The following is a description of a gene set: studied in species Homo sapiens Any process that increases the frequency, rate or extent of chromatin binding. Chromatin binding is the selective interaction with chromatin, the network of fibers of DNA, protein, and sometimes RNA, that make up the chromosomes of the eukaryotic nucleus during interphase. Human Gene Set: GOBP_POSITIVE_REGULATION_OF_CHROMATIN_BINDING, and this is the list of marker genes: DTX3L, MED25, KDM4D, GMNN, PARP9, CDT1, DDX11